Given this list of marker genes COL13A1, WASF3, PAX2, NNAT, HOXA11, CHRDL1, ADGRG2, SALL2, LYPD1, PRAME, CHST1, FOXG1, FZD7, MN1, GLI3, MEOX1, EYA1, HAS2, ETV4, CRABP2, SIX1, HOXA9, APOC1, INHBB, BRINP1, COL2A1, HMGA2, here is a description of the gene set: from publication Li CM, Guo M, Borczuk A, Powell CA, Wei M, Thaker HM, Friedman R, Klein U, Tycko B (PMID 12057921) 'Wilm's tumor signature': genes highly expressed in Wilm's tumor samples compared to normal fetal kidney and a heterologous tumor, Burkit lymphoma. studied in species Homo sapiens Human Gene Set: LI_WILMS_TUMOR Wilms' tumor (WT) has been considered a prototype for arrested cellular differentiation in cancer, but previous studies have relied on selected markers. We have now performed an unbiased survey of gene expression in WTs using oligonucleotide microarrays. Statistical criteria identified genes as differentially expressed between WTs and fetal kidneys. This set contained 124 matches to genes on a microarray used by Stuart and colleagues (Stuart RO, Bush KT, Nigam SK: Changes in global gene expression patterns during development and maturation of the rat kidney. Proc Natl Acad Sci USA 2001, 98:5649-5654) to establish genes with stage-specific expression in the developing rat kidney. Mapping between the two data sets showed that WTs systematically overexpressed genes corresponding to the earliest stage of metanephric development, and underexpressed genes corresponding to later stages. Automated clustering identified a smaller group of genes that were highly expressed in WTs compared to fetal kidney and heterologous tumor and normal tissues. This signature set was enriched in genes encoding transcription factors. Four of these, PAX2, EYA1, HBF2, and HOXA11, are essential for cell survival and proliferation in early metanephric development, whereas others, including SIX1, MOX1, and SALL2, are predicted to act at this stage. SIX1 and SALL2 proteins were expressed in the condensing mesenchyme in normal human fetal kidneys, but were absent (SIX1) or reduced (SALL2) in cells at other developmental stages. These data imply that the blastema in WTs has progressed to the committed stage in the mesenchymal-epithelial transition, where it is partially arrested in differentiation. The WT-signature set also contained the Wnt receptor FZD7, the tumor antigen PRAME, the imprinted gene NNAT and the metastasis-associated transcription factor E1AF.